Given this list of marker genes S1pr5, Fam163a, Snd1, Agap1, Zc3h7b, Sox10, Tom1l2, Fbrs, C1qtnf6, Cacnb1, Pax8, Uros, Atp6v0a2, Hnrnpab, Crb2, Nav2, Smarcb1, Ehd1, Smco3, Alx4, Mtcl2, Spred3, Adgrl1, Ccdc142, Adcy9, Zbtb7b, Limk1, Eloa (elongin A), Dusp9, Wfikkn2, Samd10, Sidt2, Gnas, Efcab2, Ap1s1, Kctd12, Inava, Ubap1, Cnot4, Adarb1, Mecp2, Zfp704, 9530068E07Rik, Crtc1, Garre1, Baiap2, Castor2, Lyn, Ermp1, Tmem132b, Nr4a1, Col5a3, Zfx, Pias2, Kcnt1, Jrk, Asic1, Sdc3, S1pr3, Lrrc28, 5031439G07Rik, Map1a, Fam163b, Grip2, Rfng, Dagla, Dapk1, Ppp1r9b, 2210016L21Rik, Stx3, Cstpp1, Zyx, Card14, Ermap, Zfp687, Prkar1b, Maml3, Elmod1, Cand2, Vdac2, Sos2, Pdzk1, Kctd17, Rnf5, Bpifc, Golga7, H2-Ob, Rere, Usp21, Rara, Mal2, Dedd2, 4921517D22Rik, Pacsin1, Rps6ka2, Shisa6, Tmem63b, Gadd45b, Arfip1 (ADP-ribosylation factor interacting protein 1), Cdc37l1, Fgf18, here is a description of the gene set: Genes predicted to be targets of miRBase v22 microRNA mmu_miR_7117_5p in miRDB v6.0 with MirTarget v4 prediction scores > 80 (high confidence targets). from publication Chen Y, Wang X (PMID 31504780) Mouse Gene Set: MIR_7117_5P species: Mus musculus